The following is a description of a gene set: species: Mus musculus from publication Tabula Muris Consortium (PMID 32669714) Mouse Gene Set: TABULA_MURIS_SENIS_TRACHEA_MACROPHAGE_AGEING, and this is the list of marker genes: Rrp1, Vasp, Eif5a, Pebp1, Gnb1, Cfl1, Tmsb10, Slc25a3, Arhgdia, Rpl6, Pfn1, Ranbp1, Comt, Rps3a1 (ribosomal protein S3A1), Psmd4, Cotl1, Snrpc, Ldha, Arpc1b, Nabp2, Jund, Dnajb1, Clta, Prelid1, Capg, Adrm1, Serbp1, Arpc3, Map2k2, Orai1, Spry2, Rpl4, Fabp5, Emc10, Fis1, Gm6402, Ly6a (lymphocyte antigen 6 family member A), Npm3-ps1, Cyb5r3, Ltb, Dcpp3, Nkiras2, Rpl14, Prr13, Bsg, Rpsa, Exosc5, Igfbp7, Ltbp4, Rplp0, Eif3f, Tle5, Il11ra1, Reep5, H2-K1 (histocompatibility 2, K1, K region), Nherf1, Rab4b, Slc25a5, Ubxn1, Lgals3, Esd, Rack1, Drap1, Cyba, Tbcb, Txn2, Psmc3 (proteasome (prosome, macropain) 26S subunit, ATPase 3), Tmed9, Rpl3, Bgn, Hsp90ab1, Rpl13a, Rps3, Lyz1, Uqcrc1, Tagln2, Tmem160